The following is a description of a gene set: species: Homo sapiens Digestion Human Gene Set: REACTOME_DIGESTION, and this is the list of marker genes: PNLIPRP1, AMY1A, LIPF (NCBI Gene Id 8513), GUCY2C, PNLIPRP3 (NCBI Gene Id 119548), GUCA2B, PNLIP, CLPS, AMY2B, CEL, CHIT1, AMY1B, GUCA2A, PIR, LCT, AMY1C, SI, TREH, PNLIPRP2, ALPI, AMY2A (NCBI Gene Id 279), CHIA, MGAM